Given this list of marker genes Ehmt1, Setdb1, Suv39h2 (suppressor of variegation 3-9 2), Ash1l (NCBI Gene Id 352974), Mecom, Prdm16, Ehmt2, Suv39h1, here is a description of the gene set: Catalysis of the reaction: N6,N6-dimethyl-L-lysyl9- + S-adenosyl-L-methionine = H+ + N6,N6,N6-trimethyl-L-lysyl9- + S-adenosyl-L-homocysteine. This reaction is the addition of a single methyl group to the dimethylated lysine residue at position 9 of histone H3, producing histone H3K9me3. Mouse Gene Set: GOMF_HISTONE_H3K9ME2_METHYLTRANSFERASE_ACTIVITY species: Mus musculus